Given this list of marker genes CALM2, CCND1, CDKN2B (cyclin dependent kinase inhibitor 2B), INSR, ERBB3, CCNB1, CNPPD1, TTN, CCDC88A, PAK2, FLT3, PRKAG2, CCNJ, NPM1, PARP8, SPRED1, PKIA, SOCS1, ATG13, PAK1IP1, CCNB3, DEPTOR, CCNI2, GMFG, SAV1, GDF2, MNAT1, SPRY4, DNAJC3, ANKRD42, MAPRE3, PRKAR1A, PPEF2, TOPBP1, STRADA, CEP43, PRKAG3, PPP1R1B, RICTOR, PDE8A, CCNG1, RHOH, GDF10, AKT1S1, TREM2, MT3, CIT, IBTK, MACROH2A1, CKS2, CCNG2, MALT1, TGFB1, HTRA2, PRKRA, NCK1, CIB1, STAP1, STRADB, CALM1, CDKN1A, WDR91, SRC, VEGFA, TAOK1, PTPRC, BTC, MAP2K2, MAP2K1, HEXIM1, LAMTOR3, KIDINS220, NGF, PKIG, DUS2, AREG, MAPK8IP2, CAV1, BMP7, AKT1, PIK3R6, STK3, PRKAR2A, GCN1, CKS1B, MADD, AXIN1, MOB3C, CAMK2N1, HSP90AB1, PRKAR2B, EREG, SH3GLB1, DAZAP2, GCKR, CCNF, ACVR2B, SOCS3, KLF4, CCNA2, CCNT2 (cyclin T2), RGCC, CAMK2N2, CCNT1, SPRED2, QARS1, DDX3X, AJUBA, RACK1, CDKN1C, RAD50, CDK4, CDK5R1, GMFB, AGAP2, RPTOR, BMP2, TRIB1, CCNK, CCNE1, CCL5, MOB2, ANGPT4, FERMT2, PIK3R2 (NCBI Gene Id 5296), CCNY, HTR2A, PPP5C, HSPA5, CDC37, CCNL1, CCNO, IGF2 (NCBI Gene Id 492304), CD24, TGFBR2, EPGN, PRKAG1, BCL10, DAXX, PIK3R5, SH3BP5L, BMP4, CCNP, NEK9 (NCBI Gene Id 91754), ALK, ANKLE2, MARK2, CCNE2, ACSL1, PRKD1, CCNH, MAP3K12 (NCBI Gene Id 7786), KAT2B, DBF4B, IRS2, MAP3K20, DUSP22, STK4, YWHAG, PIK3R1, SPDYA, TESC, DBF4, TESK1, CDKN1B, SPRY2, PARVA, TPX2, CAB39, GPRC5C, TRIB2, PARP6, PKIB, ETAA1, GRM5, CCNJL, MOB1B, MOB3B, SMO, CCNB2, NRG1, PYDC1, NCKAP1L, SH3BP5, INKA2, MOB1A, GSTP1, MTCP1, SLC27A1, CALM3, LYN, IL2, HMGB1, PIK3R3, BCCIP, PPP2R5A, TAOK3, CCKBR, CCND3, ALKAL2, CDKN2D, PRKRIP1, GPRC5B, ALS2, GSKIP, WASHC1, PIM1, EFNA5, WNT11 (Wnt family member 11), PIK3CA, PIK3IP1, CD40LG, PRKAR1B, DUSP3, GPRC5D, RUBCN, GHRL, ATAD3A, TCL1A, STK11, EGF, ELP4, ABI1, ERCC6, PARP16, WARS1, GREM1, HSPB1, CCNA1, MAP3K13, TRIB3, DAB2IP, LRP6, EGFR, CSNK2B, SAMD15, LILRB4, IQGAP1, SNCA, WDR81, IRGM, MSTN (NCBI Gene Id 2660), EEF1A1, GPRC5A, INCA1, FAF1, CXCL10, APC, HYAL2, CCNI, GHR, SMCR8, MAPK8IP1, CDK5R2, AFAP1L2, TCL1B, PREX1, LTF, RHEB, RPLP1, IL6ST, CCNL2, PRKCH, INKA1, TNKS1BP1, MOB3A, NRG3, CCND2, ALKAL1, TAOK2, CDKN2C, ADIPOQ, SFN, CCNC, CDKN2A, RAC2, ELP3, ATG14, MBIP, MLST8, PREX2, CASP3 (NCBI Gene Id 836), EPO, CCNQ, TOM1L1, HBEGF, DGKQ, HEXIM2, FAM20A, DELE1, CHP1, CAB39L, AHSG, ANKRD54, RANBP2, LTK, WNK1, DUSP19, IGF1, TAB1, ITPRIP (NCBI Gene Id 85450), NBN, YWHAB, TGFA, here is a description of the gene set: Human Gene Set: GOMF_KINASE_REGULATOR_ACTIVITY studied in species Homo sapiens Modulates the activity of a kinase, an enzyme which catalyzes of the transfer of a phosphate group, usually from ATP, to a substrate molecule.